The following is a description of a gene set: Eicosanoid metabolism via cyclooxygenases (COX) species: Homo sapiens Human Gene Set: WP_EICOSANOID_METABOLISM_VIA_CYCLOOXYGENASES_COX, and this is the list of marker genes: ACAA1, CYP4F12, PTGIR, PRXL2B, ACOX1, PTGES, PTGR1, PTGIS (NCBI Gene Id 5740), TBXA2R, PPARD, PTGR2 (NCBI Gene Id 145482), ACOX3, CYP4A11, PTGS2, PLA2G4A, AKR1B1, PTGDR, PTGS1, PLA2G6, PTGFR (NCBI Gene Id 5737), PPARG, ACOX2, PLA2G5, EHHADH, CYP4F2, PTGDR2 (NCBI Gene Id 9484), PTGDS, CYP4A22, PLA2G4B, TBXAS1, HPGD